The following is a description of a gene set: Reactome Pathway: tRNA processing in the nucleus part of: tRNA processing studied in species Homo sapiens Genes encoding transfer RNAs are transcribed in the nucleus by RNA polymerase III. (Distinct processes of transcription and processing also occur in mitochondria.) The initial transcripts, pre-tRNAs, contain extra nucleotides at the 5' end and 3' end. 6.3% (32 of 509) of human tRNAs also contain introns, which are located in the anticodon loop, 3' to the anticodon. The additional nucleotides are removed and a non-templated CCA sequence is added to the resulting 3' terminus by processing reactions in the nucleus and cytosol.<br>The order of processing and nucleotide modification events may be different for different tRNAs and its analysis is complicated by a retrograde transport mechanism that can import tRNAs from the cytosol back to the nucleus (retrograde movement, Shaheen and Hopper 2005, reviewed in Phizicky 2005). Generally, the 5' leader of the pre-tRNA is removed first by endonucleolytic cleavage by the RNase P ribonucleoprotein complex, which contains a catalytic RNA (RNA H1 in humans) and at least 10 protein subunits.<br>The 3' trailer is then removed by RNase Z activity, a single protein in humans. ELAC2 is a RNase Z found in both nucleus and mitochondria. ELAC1 is found in the cytosol and may also act as an RNase Z. Human tRNA genes do not encode the universal acceptor 3' terminus CCA, instead it is added post-transcriptionally by TRNT1, an unusual polymerase that requires no nucleic acid template.<br>In humans introns are spliced from intron-containing tRNAs in the nucleus by a two step mechanism that is distinct from mRNA splicing. The TSEN complex first cleaves 5' and 3' to the intron, generating a 2'3' cyclic phosphate on the 5' exon and a 5' hydroxyl group on the 3' exon. These two ends are ligated by a complex containing at least 6 proteins in a single reaction that both hydrolyzes the 2' phosphate bond and joins the 3' phosphate to the 5' hydroxyl. (In yeast the ligation and the hydrolysis of the 2' phosphate are separate reactions. The splicing reactions in yeast occur in the cytosol at the mitochondrial outer membrane.) <br>Mature transfer RNAs contain a large number of modified nucleotide residues that are produced by post-transcriptional modification reactions. Depending on the specific tRNA these reactions may occur before or after splicing and before or after export from the nucleus to the cytosol., and this is the list of marker genes: NUP210, NUP43, RPP40, POP1, NUP37, POP4, NUP160 (nucleoporin 160), POM121C, NDC1, FAM98B, NUP35, RPP25, POP5, CSTF2, TSEN54, RTCB, NUP88 (NCBI Gene Id 4927), RAN, NUP133, CPSF4, CPSF1, NUP205, NUP155, RPP21, ELAC2, AAAS, POP7, TSEN2, ZBTB8OS, NUP42, TPR, RAE1, RANBP2, SEH1L, RTRAF, RPP30, CLP1, NUP85, RPP38, NUP214, C2orf49, NUP153, NUP93, POM121, RPP14, TRNT1, DDX1, NUP188, NUP98, TSEN15 (tRNA splicing endonuclease subunit 15), NUP58, NUP54, NUP107, TSEN34, NUP62, XPOT, SEC13, RPPH1, NUP50